Given this list of marker genes PROKR2, CLDN16, GINS1, CDK14, HARS2, NAP1L1, TMEM161B, ZNF713, MLLT3, FMNL1, RBM26, FDFT1, NEO1, NHLH2, RANBP10, PPM1B, NOM1, AFAP1L2, MBD4, UNC13C, MSL3, USH2A, SHOC2, EMSY, AIG1, RS1, ARMCX5, PI15, ZC3H4, HNF4G, ZBTB2, SERF2, IKZF2, ARID1A, MYLK4, CCDC28A, COL9A1, ZNF653, CNTNAP3B, ZNF649, PPAT, CAMK2G, EDIL3, ATP1B3, BOD1L1, CAPN7, CAV2, ZFYVE28, ZBTB5, POC1B, EGR3, DCP1B, PTHLH, CCNJ, SGCD, PHF20L1, KLF9, PPP4R2, PAK1, TMSB4Y, CLDN12, DIXDC1, ZCCHC24, SORBS2, CADM2, TMEM255A, AGO1 (argonaute RISC component 1), TRMT9B, DEPDC1, PLRG1, CFL2 (NCBI Gene Id 1073), NUFIP1, KATNAL2, PELO, UTY, TRIAP1, BEX3, ASTN2, MST1L, HOOK1, OTUD4, TSPAN2, ADIPOR1, CDH6, ST8SIA2, CSK, WDR31, ARMT1, SLC66A3, DMXL2 (Dmx like 2), FGFR1OP2, TMIGD1, FAM135B, MACO1, ZNF528, CLASP1, JAK2, SPEF2, SSX2IP, RC3H1, CHMP1B, BMPR1A, C1GALT1, NETO1, ZBTB7A, ZMYND11, EML4, GATAD2B (NCBI Gene Id 57459), HACD3, TCEAL6, CMPK1, BMP10, ORC4, MEGF10, NUP155, RGS6, NSUN6, HTR2C, AMMECR1L, C8orf58, ZNF652, CAPZA2, DEPDC4 (NCBI Gene Id 120863), IKBIP, NPAS2, ELF1, ARMC5, CUX2, APOOL, UPRT, UBE2V2, JMY (junction mediating and regulatory protein, p53 cofactor), SLC16A7, LURAP1L, PLEKHA5, here is a description of the gene set: species: Homo sapiens Genes predicted to be targets of miRBase v22 microRNA hsa-miR-216a-5p in miRDB v6.0 with MirTarget v4 prediction scores > 80 (high confidence targets). from publication Chen Y, Wang X (PMID 31504780) Human Gene Set: MIR216A_5P